The following is a description of a gene set: studied in species Homo sapiens An array of inositol trisphosphate (IP3) and tetrakisphosphate (IP4) molecules are synthesised by the action of various kinases and phosphatases in the cytosol (Irvine & Schell 2001, Bunney & Katan 2010). Reactome Pathway: Synthesis of IP3 and IP4 in the cytosol part of: Inositol phosphate metabolism, and this is the list of marker genes: PLCH2, PLCB4, PLCD4, PLCG1, INPP5B, CALM1, PLCE1, PLCB3, PTEN, PLCD1, INPP5D, ITPKC, ITPKB, PLCB2, PLD4, PLCB1, PLCD3, ITPK1, PLCG2, ITPKA, INPPL1, PLCH1, OCRL, SYNJ1, PLCZ1, INPP5J